Given this list of marker genes Map3k7 (NCBI Gene Id 93774), Arhgef5, Map2k7, Ager, Fzd8, Bcl10, Tirap, Fcer1a, Map3k13, Axin1, Traf6, Map4k2, Tlr6, Sash1, Map3k11 (NCBI Gene Id 76541), Edn1, Rps3, Map3k4, Fzd5, Tnfrsf11a, Pak1, Fzd4, Zeb2, Tnf, Map3k5, Syk (NCBI Gene Id 20963), Ccl19, Ern1, Taok3, Vangl2, Dvl2, Map3k1, Ccr7, Ern2, Map3k12, Dusp19, Map2k4, Traf2, Irak1, Mapk8ip3, Fgd4, Magi3, Map3k10, Epha4, Wnt5a, Dab2ip, Ptpn1, Fgd2 (NCBI Gene Id 26382), here is a description of the gene set: Mouse Gene Set: GOBP_POSITIVE_REGULATION_OF_JUN_KINASE_ACTIVITY studied in species Mus musculus Any process that activates or increases the frequency, rate or extent of JUN kinase activity.